The following is a description of a gene set: part of: Diseases of Immune System Reactome Pathway: Diseases associated with the TLR signaling cascade species: Homo sapiens Toll like receptors (TLRs) are sensors of the innate immune system that detect danger signals derived from pathogens (pathogen-associated molecular patterns - PAMP) or damaged cells (damage-associated molecular patterns - DAMP) (Pasare C and Medzhitov R 2005; Barton GM and Kagan JC 2009; Kawai T and Akira S 2010). Signaling by these sensors promotes the activation and nuclear translocation of transcription factors (IRFs, NFkB and AP1). The transcription factors induce secretion of inflammatory cytokines such as IL-6, TNF and pro-IL1beta that direct the adaptive immune response. Inherited or acquired abnormalities in TLR-mediated processes may lead to increased susceptibility to infection, excessive inflammation, autoimmunity and malignancy (Picard C et al. 2010; Netea MG et al. 2012; Varettoni M et al. 2013). Here we describe four primary immunodeficiency (PID) disorders associated with defective TLR-mediated responses. First, MyD88 or IRAK4 deficiency is characterized with a greater susceptibility to pyogenic bacteria in affected patients (Picard C et al. 2003; von Bernuth H et al. 2008). Second, defects in the TLR3 signaling pathway are associated with a greater susceptibility to herpes simplex virus encephalitis (Zhang SY et al. 2013). Third, imunodeficiencies due to defects in NFkB signaling components are linked to impaired TLR-mediated responses (Courtois G et al. 2003; Fusco F et al. 2004). Finally, events are annotated showing constitutive activation of a somatically mutated MyD88 gene which results in malignancy (Varettoni M et al. 2013)., and this is the list of marker genes: IKBKG, TLR5, CHUK, LY96, NFKB1, TICAM1, TLR3, NFKB2, TLR6, fliC, FGB, FGG, TLR2, HMGB1, UNC93B1, BTK, CD36, S100A8, TIRAP, TLR1, porB, CD14, FGA, TLR7, RELA, IRAK4, MYD88, S100A9, S100A1, mip, NFKBIA, TRAF3, TLR4, TLR10, IKBKB